Given this list of marker genes JAK2, PLAGL1, C2orf69, RBM15B, PLCL1, TP53INP2, STAG2, ZEB2, VGLL4, SEC24A, ADNP2, COG5, EBF2, RAP2A, OSBPL11, LAPTM5, CMTM6, UQCR10, DENND1B, AP1S2, LINC02873, GPR82, PARD6B, KMT2E, MTUS1, C7, TRA2A, FAM199X, CCAR1, MPRIP, CAMK2N1, IL24, PPP4R2, PI15, HNRNPU, ADGRG6, RBM12B, SMARCAD1, ADH5, REV1, ELMOD1, NSG2, TBC1D8B, TAF4 (NCBI Gene Id 6874), ZFP36L1, CD58, TBC1D25, CBX1, LNX1, SDC4, ULBP2, FEM1C, AKIRIN2, BLTP3A, RELA, ZDHHC2, WASHC4, MICU2, BRWD1, PRKG1, WDR26, DGKH, PSAT1, VWA2, RCOR3, PLPP3, IGF2R, AK6, NUDT4, MAPK1IP1L, HMGCLL1, UBE2E3, TTF1, KLF3, PLXNC1, S100PBP, HMG20A, SNTB1, TMX4, ADAM10, PI4KB, MED13, CNTN4, DENND5A, ZNF226, SHISA6, NFKBIZ, ANKRD17, ABHD13, TBC1D22B, WBP1L, CTCF, TGFBR1, VPS13C, ITGB1, FAM120B, DENND1A, MAT1A, TUT4, F2RL1, NUP93, NETO1, TAOK1, NUFIP2, SALL3, RNF144A (NCBI Gene Id 9781), TUBGCP5 (NCBI Gene Id 114791), BTBD3, ECT2, HORMAD2, EXOG, PKIB, FOXJ3, LOX, TRIM24, EML1, PPEF1, SULT4A1, P2RY8, MMD, here is a description of the gene set: Human Gene Set: MIR888_3P species: Homo sapiens Genes predicted to be targets of miRBase v22 microRNA hsa-miR-888-3p in miRDB v6.0 with MirTarget v4 prediction scores > 80 (high confidence targets). from publication Chen Y, Wang X (PMID 31504780)